Given this list of marker genes Igf1r, Cela1, Xbp1, Igf1, Igf2 (insulin-like growth factor 2), Srp54a, Wls, Ptf1a, Insr, Nr5a2, Pdx1, here is a description of the gene set: The process whose specific outcome is the progression of the exocrine pancreas over time, from its formation to the mature structure. The exocrine pancreas produces and store zymogens of digestive enzymes, such as chymotrypsinogen and trypsinogen in the acinar cells. Mouse Gene Set: GOBP_EXOCRINE_PANCREAS_DEVELOPMENT studied in species Mus musculus